The following is a description of a gene set: A process that is carried out at the cellular level which results in the assembly, arrangement of constituent parts, or disassembly of a peroxisome. A peroxisome is a small, membrane-bounded organelle that uses dioxygen (O2) to oxidize organic molecules. studied in species Mus musculus Mouse Gene Set: GOBP_PEROXISOME_ORGANIZATION, and this is the list of marker genes: Pex7, Opa1, Mavs (NCBI Gene Id 228607), Pjvk, Pex11b, Abcd1, Acot8, Pex26, Pex13, Usp9x, Abcd3, Pex5, Pex12, Fis1, Mff, Dnm1l, Trim37, Pex6, Lonp2, Pex2, Zfand6, Hacl1, Pex1, Pex10, Pex11g, Pex16, Pex3, Pex5l, Pex19 (NCBI Gene Id 19298), Pex11a, Rab8b, Plaat3, Abcd2, Acox1, Sec16b, Tmem135, Abcd4, Pex14, Plaat1